Given this list of marker genes MSANTD2, HNRNPUL2, CBX7, SIAH1, KIT, NF2, RGMA, MAPK10, NT5E, CLOCK (clock circadian regulator), IGFBP5, SRSF2, AREL1, OSMR, CCDC28A, DNAAF4, DMXL2, CADM1, USP53, KCNJ2, ZBTB25, ZMAT3, PLAG1, FHDC1, AP2M1, UBP1, ABCB8, KRAS, CREBRF, TIMM8B (NCBI Gene Id 91900), RRAS2, ETS1, FAT4, TGFBR3, GPR20, EPHA5, TAOK1, INO80D, CNOT6, ETV1, HEG1, RBMXL1, WDR82, FLI1, RUNX1T1, RAPGEF6, AJUBA, ATF7IP2, CARF, LAMC1, UPRT, EARS2, ST6GALNAC5, PLCH1 (phospholipase C eta 1), CYREN, LAMC2, ERBB4, ZNF618, VN1R1, TSC1, CCND1, SLC10A6, TAPT1, IL17RD, PLAU, NAV3, ADARB1, ADGRE5, ARHGEF12, MARF1, SOS2, DCAF7, SLC16A6 (solute carrier family 16 member 6), AIMP2, P2RX5, PLXNC1, ABI2, YWHAZ, LRP4, HOXD13, LYRM2, PIGA, CLTC, AAK1, here is a description of the gene set: Human Gene Set: MIR193A_3P_MIR193B_3P studied in species Homo sapiens from publication Chen Y, Wang X (PMID 31504780) Genes predicted to be targets of miRBase v22 microRNA hsa-miR-193a-3p, hsa-miR-193b-3p in miRDB v6.0 with MirTarget v4 prediction scores > 80 (high confidence targets).